Given this list of marker genes Pmepa1, Cd55, Hif1a, Hecw2, Msl2, Mapk8, Cnih3, Chst11, Bnip3l, Slc30a4, Pafah1b1, Kdm7a, Ttc5, Inpp4b, Ndst3, Pex13, Dennd4a, Zfp407, Stk17b, Dppa3, Fbxo5 (NCBI Gene Id 97658), Unc79, Prkcb, Nhlrc2, Esr1, Mttp, Lrpap1, Trpc5os, Atxn7 (ataxin 7), Chp1, Psme3ip1, Adnp2, Adamts6, Sh3rf1, Stat1, Coq10b, Gtf2h1, Bivm, Lpgat1, Shprh, Cbfb, Sema5a, Atp8b1, Pja2, Caap1, B3galt1, Ptgs2, Tmem128, Prpf38b, Pld1, Prkar2b, Csmd3, Lins1, Srsf3, Pias2, Lancl1, Mrgprb2, Cyrib, Rc3h1, Btg2, Scai, Tmem39a, Tlk1, Pde7a, Smg1, Tasp1, Sarnp, Dtl, Fut10, Sp3, Chrdl1, Cpne3, Glrb, Mafg, Foxf2, Marchf6, Eif4ebp2, Acap2, Spag16, Irf2, Ppp1r3a, Ppp2r5e, Smurf2, Oaz1, Hcn1, Ulk1 (NCBI Gene Id 22241), Lgr5, Cyp2c55, Gmfb, Fyttd1, Serinc3, Luc7l3, Nars1, Strn3, Rad23a, Fgl2, Dner, Fgd4, Larp4, Trpc1, Pcmtd1, Pnpla8, Dennd5b, Suox, Mbd6, Cdkl4, Uck2, F2r, Gucy1a1, Fubp1, Cnot6, Cbln2, Jag1, Fip1l1, Man1a2, Pdia4, Mindy3, Mgll, Pak3, Nab1, Zfp110, Dmtf1l, Dbp (NCBI Gene Id 13170), Clec4d, Myo9a, Zranb2, Zfp446 (NCBI Gene Id 269870), Dlg1, AY074887, Zkscan8, Kcnb1, Ydjc, Tlcd4, Mybl1, Saxo2, Ttc19, Plxna2, Hapstr1, Pde5a, Abcg3, Ints10, Orc6, Ago1, Rbms3, Rag1, Mrtfb, Ptp4a2, Eloc, here is a description of the gene set: from publication Chen Y, Wang X (PMID 31504780) Mouse Gene Set: MIR_302A_5P Genes predicted to be targets of miRBase v22 microRNA mmu_miR_302a_5p in miRDB v6.0 with MirTarget v4 prediction scores > 80 (high confidence targets). studied in species Mus musculus